The following is a description of a gene set: Human Gene Set: HP_CALCIFICATION_OF_FALX_CEREBRI Calcification of falx cerebri studied in species Homo sapiens The presence of calcium deposition in the falx cerebri., and this is the list of marker genes: SUFU, COL11A1, ZSWIM6, PTCH2, PTCH1, ABCC6, DDR2